The following is a description of a gene set: from publication Hay SB, Ferchen K, Chetal K, Grimes HL, Salomonis N (PMID 30243574) Human Gene Set: HAY_BONE_MARROW_CD34_POS_ERP species: Homo sapiens, and this is the list of marker genes: PCAT18, RYR3-DT, FAM124B, TRIB2, NET1, STAT5A, RYR3, MEST, SERPINE2, MAP7